The following is a description of a gene set: Human Gene Set: HP_CALVARIAL_SKULL_DEFECT Calvarial skull defect species: Homo sapiens A localized defect in the bone of the skull resulting from abnormal embryological development. The defect is covered by normal skin. In some cases, skull x-rays have shown underlying lytic bone lesions which have closed before the age of one year., and this is the list of marker genes: DOCK6, ALX4, BMS1, NSD2, KCTD1, RBPJ, FRAS1, PAK2, GRIP1, WNT7A, CTBP1, NOTCH1, ARHGAP31, UBA2, DLL4, UBR1, LETM1, CPLX1, PIGG, PLEC, POLR1A, COL18A1, NELFA, HSPG2, FREM2, EOGT, ITGB4, LBR